The following is a description of a gene set: Genes up-regulated in blood responders vs poor responders in adults (25-83) (responders) after exposure to Twinrix, time point 0D Aging is associated with hyporesponse to vaccination, whose mechanisms remain unclear. In this study hepatitis B virus (HBV)-naive older adults received three vaccines, including one against HBV. Here we show, using transcriptional and cytometric profiling of whole blood collected before vaccination, that heightened expression of genes that augment B-cell responses and higher memory B-cell frequencies correlate with stronger responses to HBV vaccine. In contrast, higher levels of inflammatory response transcripts and increased frequencies of pro-inflammatory innate cells correlate with weaker responses to this vaccine. Increased numbers of erythrocytes and the haem-induced response also correlate with poor response to the HBV vaccine. A transcriptomics-based pre-vaccination predictor of response to HBV vaccine is built and validated in distinct sets of older adults. This moderately accurate (area under the curve ~65%) but robust signature is supported by flow cytometry and cytokine profiling. This study is the first that identifies baseline predictors and mechanisms of response to the HBV vaccine. studied in species Homo sapiens from publication Fourati S, Cristescu R, Loboda A, Talla A, Filali A, Railkar R, Schaeffer AK, Favre D, Gagnon D, Peretz Y, Wang IM, Beals CR, Casimiro DR, Carayannopoulos LN, Sékaly RP (PMID 26742691) Human Gene Set: FOURATI_BLOOD_TWINRIX_AGE_25_83YO_RESPONDERS_VS_POOR_RESPONDERS_0DY_UP, and this is the list of marker genes: UGT8 (NCBI Gene Id 7368), C14orf28, NBEA, DOCK9, ZNF135, PSG11, SPTBN1, CT47A11, COBLL1, ZXDA, SLC16A10, STAMBPL1, ANK3, CD40, ZNF107, VEGFD, RAB30, C1orf220, API5, LINC00879, MDFIC, AGPAT5, MLLT3, PCDH9, RBMX, METAP1D, FOXP1, ZNF140, EDA2R, SLC7A6OS, TMEM35A, WDR44, GSTM3, PRSS1, EGLN3, FAM226B, PABIR2, RORA, MTRR, HSPD1, GOLGA8T, GNG7, PCDH19, SNX22, NR3C2, POFUT1, BCL2, WNK3, IKZF1, FAM13A, PLPP5, NUBPL, ZNF626, PRDM2, WFDC10A, HLA-DRB1, EFHC2, CTAGE15 (CTAGE family member 15), RABGAP1L, HLF, TRIM2, ZNF519, ERP44, PKIG, GTDC1, TPD52, ZMAT1, ZNF529, CASK, MRPS35, BHLHE41, TAF7, PTER, CD79A, PPP2R1B, MIR507, SMARCE1, ANKRD36, RNFT2, BCLAF1, PURA, RNF185, TRAF5, HNRNPC (heterogeneous nuclear ribonucleoprotein C), NOX1, NUDT7, SPART, GPM6B, IGHM, TMSB15B, RPS4X, SLC9A7, RLIG1, ABCB4, TMEM263, ANKRD36C, PRKACB, CYP2E1, ABLIM1, POM121C, SEPTIN6, S1PR1, FAM177B, ZNF548, LRRN3, AIDA, TLK1, AMMECR1, AP4S1, RRAS2, ZNF614, LDHB, TSEN2, PHF10, PRPS2, XPO1, FBXW11, CCDC160, ENAM, YWHAQ, IGHG1, OR6C3, TRPC5, TAB2, SERPINB11, FAM9A, FAHD1, OSBPL10, LPAR4, ATRX, ZNF550, KLHL4, ANP32E, FANCB, SPIB, IGFBP5, SKIC3, EMC3-AS1, NUFIP1, VCF2, DYRK1A, ZNF518B, SLC4A5, ATF1, TSPAN13, KAT6B, POLA1, SMIM10 (NCBI Gene Id 649943), MS4A1, SGCE, ITPR1, ZNF837, CD72, FAM120C, ASNS, DLAT, NBDY, HIVEP2, INSIG1, TBC1D8B, IL24, NCBP2, NBPF11, DMD, ZNF566, ZCCHC7, CD79B, FXR1, ADAM28, MFSD4A, PRRG1, VPS4B, CWC22, CCDC91, GFOD3P, HNRNPA0 (NCBI Gene Id 10949), PHLDA1 (NCBI Gene Id 22822), EML4 (NCBI Gene Id 54548), ZDHHC23, IGLC1, ZNF507, MECOM, KICS2, TAF1, ZNF442, ENSG00000289047, PPP6C, KCNH8, TRIB2, DDX21, CTH, SMURF2, CT47A2, UBQLN1, TSEN15, CLEC2D, LEKR1, ZNF470, GPR18, GNG13, TMEM220, GPRASP3, EIF5, FBXL16, RSPRY1, RAD54B, KBTBD8, SLC38A1, TCERG1 (NCBI Gene Id 10915), SLC25A6, BDH2, ARHGEF3, ADAM30, MORF4L2, BMI1, FCER2, SYTL5, ANGPTL1, USP9X, PTPRK, GPR183, HSP90AB1, REEP5, IFT43, BCAS2, CDK17 (cyclin dependent kinase 17), NLGN4X, ARL6IP5, DCX, SEPTIN7, ATP11C, ZNF420, CELSR1 (NCBI Gene Id 9620), KHDRBS1, PMEPA1, TMEM47, XIST, ARHGAP42, GPR82, SEL1L3 (NCBI Gene Id 23231), ZNF331, DPP4, ANAPC16, CCNG1, PAIP2B, PAWR, ZNF253 (NCBI Gene Id 56242), ADGRG4, USP51, ADAM22, HECA, TFDP3, OR2L2 (NCBI Gene Id 81467), COMMD3-BMI1, CHM, EGFL6, CLCN5, TCEA1 (NCBI Gene Id 7865), FHIP1A, TAF4B, FAM3C, BCL11A, BLNK, SLC25A4, TCEANC, NLGN1, FRA10AC1, SPICE1, NETO1, HEPH, MYO5B, CTAGE9, KDM5C, PSIP1, NUDT11, ARL14EP, IRAK1BP1, PHF6, DTD2, SHISAL2A, DSP (desmoplakin), POM121, SSX2, SKP1 (S-phase kinase associated protein 1), MTR, TTC3, BTLA, CT47A1, NUDT10, ZNF251, PARM1, MUC20, KDM6A, POU2AF1, ZNF44, DNM1L, GRPEL2, SSPN, IRF8, HLA-DRB3, RERG, RYK, CHML, BCL7A, CLIC4, OFD1, ZNF141, RASGRP3, OR2A42, FAM199X, NUP62CL (nucleoporin 62 C-terminal like), GRIA3, BLK, TAGAP, NAP1L1, OCIAD1, FRMPD4, GEMIN8, USP27X-DT, CPO (carboxypeptidase O), CHN1, GCSAM, MED14, MTMR2 (myotubularin related protein 2), G3BP2, ADAM21, FGA, PEG10, PJA1, STAP1, SMIM11, SARAF, TENM1, AMOTL1, FHOD3, BCLAF3, SLC25A32, STRBP, AGA-DT, CXCR5, EBF1, DACT1, DNAJC30, LEF1, ZXDB, ALDH1A3, PM20D2, CD160, CFAP44, DOCK10, ITM2A, MYOT, CBLL1 (Cbl proto-oncogene like 1), TBX20, FAM9C, BACH2, GDPD1, ADD3, CT47A10, SCN3A, APOO, NHLRC2 (NHL repeat containing 2), MXRA5, CD27, DDX3X, FOXE1, LHX6, SET, CCR6, DNAH3, ARMC1, COCH, ZNF667, PLP1, MRTFB, ABCB11, SPRR2B, RASGRP1, TRAPPC2, MIPOL1, ARB2A, SMAD3, MAP7D2, POU2F3, BTNL9, CNTNAP1, HLA-DQB1, CTAGE4, ZNF711, LARGE2, SPON1, MBTPS2, FAM107B, TTC39C (tetratricopeptide repeat domain 39C), AHR, TSPYL1, USP27X, TCF7, CD22, MID2, CHIC1, CLU (clusterin), PTHLH, IL7R, KLF12, TCTN1 (tectonic family member 1), CXorf58, ZNF268, MALT1, FSD1L, CTAGE6, LINC01550, FCRLA, METTL4, FOXO1, RBM12, SNAPC3, ZNF280C, SLC38A11, SMARCA1, RABL3, BUB3, THEM4 (thioesterase superfamily member 4), FAM30A, NPHP1, SMC6, MROH2A, MRPL39, KLHL14, NEMP1, PDGFB, RPS6KA6, AFF3 (ALF transcription elongation factor 3), AR, NIPAL3, DNAAF6, OPHN1, CNR2, ZNF615, MOXD1, EML6, FMR1NB, CD180, NIBAN3, WDR6, RALGPS2, GABPA (NCBI Gene Id 2551), FCRL2, EIF2S3, WDR3, ATP2B3, CFAP47, CATSPERB, TMPO, MBNL1, USP6, LINC00926, DLG5, HSPA8, PTGES3, LINC02397, PLEKHF2, MAGEA6, ALDOB, IL7, STK17A, ZNF525, NEXMIF, TPD52L1 (TPD52 like 1), ITGA6, MAGEA3, ZFX, HLA-DOB, TBC1D9, ANAPC1, SMPX, CGGBP1, BIRC3, FCRL1, COL4A4, ATM, P2RX5, CDR1, PLEKHB1, ACSM1, LINC00891, IRF4, SLC2A12, LRCH1, ID3, EPM2A (NCBI Gene Id 7957), ANKRD13C-DT, C19orf12, IGHG2, MAGEA5P, AXIN2, NAP1L2, EXOG, ATP1B4, ZNF92, TCL6, SLITRK2, SLITRK4, SPRY1, IGHD, TBC1D4, NDP, ZNF320, FCGR2B, SWAP70, SH3BGR, SNORD61, EIF4B, TENM3, DNAH12, PDK2, ST6GAL1, CLN8, SYPL1, PAK3, TXLNG, WWP1, HNRNPR, ENPP5, SLC35G1, ICE1, TNFRSF13C, EDARADD, ANKRD36B, EIF1AX, ZNF418, GAGE1, ZBTB6, SERBP1, OGT, TNFRSF25, CFAP97, KCNE2, MATR3, PKHD1L1, HMGB1, FAM9B, TRIM67, SNORD45B, NARS2, PREX2, EEIG1, PRKCQ-AS1, PODXL, PLS3, TRAM1, CD200 (NCBI Gene Id 4345), RPL22, CDC42SE2, CT55, DCK, METTL8, CR2, ZFR, EFR3A, OR2A1, RASL11B, PLEKHG1, SELENOI, SERPINE3, BPNT1, EIF3L, TMEM230, VPREB3, ZNF382, EEF1G, QRSL1, HEPHL1, LIX1, MOSPD2, PPP1R21 (NCBI Gene Id 129285), ZBTB33, NT5E, PHC3, ZNF582-DT, LARGE1, FCMR, PRICKLE1, BANK1, FAM13B, RAP2C, MAGT1